The following is a description of a gene set: Human Gene Set: HP_SLOW_PUPILLARY_LIGHT_RESPONSE species: Homo sapiens Slow pupillary light response Reduced velocity and acceleration in the pupillary light response., and this is the list of marker genes: TUBB3, PCYT1A (NCBI Gene Id 5130), SPATA7, RDH12, KIF21A, RPE65, GDF6, COL18A1, GALC, MPZ, IFT140, LCA5, LRAT (NCBI Gene Id 9227), USP45, AIPL1, PRPS1, LAMB2, COLQ, CEP290, CRX, NMNAT1, IMPDH1, PMP22, RD3, IQCB1, GUCY2D, CHRM3 (NCBI Gene Id 654136), CHRNA3, RPGRIP1, PSAP, KCNJ13, AIMP1, TULP1, CRB1, COL25A1, TUBB2B, PHOX2A, TUBA1A, TUBB4B